The following is a description of a gene set: studied in species Mus musculus Susceptibility to Crohn's disease, a complex inflammatory disease involving the small intestine, is controlled by over 30 loci. One Crohn's disease risk allele is in ATG16L1, a gene homologous to the essential yeast autophagy gene ATG16 (ref. 2). It is not known how ATG16L1 or autophagy contributes to intestinal biology or Crohn's disease pathogenesis. To address these questions, we generated and characterized mice that are hypomorphic for ATG16L1 protein expression, and validated conclusions on the basis of studies in these mice by analysing intestinal tissues that we collected from Crohn's disease patients carrying the Crohn's disease risk allele of ATG16L1. Here we show that ATG16L1 is a bona fide autophagy protein. Within the ileal epithelium, both ATG16L1 and a second essential autophagy protein ATG5 are selectively important for the biology of the Paneth cell, a specialized epithelial cell that functions in part by secretion of granule contents containing antimicrobial peptides and other proteins that alter the intestinal environment. ATG16L1- and ATG5-deficient Paneth cells exhibited notable abnormalities in the granule exocytosis pathway. In addition, transcriptional analysis revealed an unexpected gain of function specific to ATG16L1-deficient Paneth cells including increased expression of genes involved in peroxisome proliferator-activated receptor (PPAR) signalling and lipid metabolism, of acute phase reactants and of two adipocytokines, leptin and adiponectin, known to directly influence intestinal injury responses. Importantly, Crohn's disease patients homozygous for the ATG16L1 Crohn's disease risk allele displayed Paneth cell granule abnormalities similar to those observed in autophagy-protein-deficient mice and expressed increased levels of leptin protein. Thus, ATG16L1, and probably the process of autophagy, have a role within the intestinal epithelium of mice and Crohn's disease patients by selective effects on the cell biology and specialized regulatory properties of Paneth cells. Genes up-regulated in Paneth cell (part of intestiinal epithelium) of mice with hypomorphic (reduced function) form of ATG16L1. Mouse Gene Set: CADWELL_ATG16L1_TARGETS_UP from publication Cadwell K, Liu JY, Brown SL, Miyoshi H, Loh J, Lennerz JK, Kishi C, Kc W, Carrero JA, Hunt S, Stone CD, Brunt EM, Xavier RJ, Sleckman BP, Li E, Mizushima N, Stappenbeck TS, Virgin HW 4th (PMID 18849966), and this is the list of marker genes: Inmt (indolethylamine N-methyltransferase), Ifit1bl2, Kctd14, Cyp2e1, Smyd1, Lhfpl2, Amy1, Apoc2, Bst1, Selenos, Upk1b, Npr3, Cst6, Ifit1bl1, Dhh, Gsdmc2, Tmem87a, Zkscan1, Rbp4, Scd1, Ggt1 (NCBI Gene Id 14598), G530011O06Rikx, Wfikkn2 (WAP, follistatin/kazal, immunoglobulin, kunitz and netrin domain containing 2, NCBI Gene Id 70468), Gsdmc4, Ssr1, Fmn2, Cd163, Car3, Etnppl, Xist, Rbm45, Plekhm1, Chst1, Wdfy1, Hbb-bs, Lpl, Thrsp, Alpi, Vnn1, Cfd, Cfi, Retnla, Exosc10, Ptger3, 2900026A02Rik, Cxcl1, Fcgrt, Sucnr1 (succinate receptor 1), Cit, Hba-a1, C1qtnf1, Ccdc80, Akr1b7, Adipoq, Serpina10, Neurod2, Plin1, Rhov, Hp, Gzmb, Ap1m1, Cidec, Rsad2, Lep, Tha1, Npc1l1, Ifit1, 4931408D14Rik, Gm30613, ENSMUSG00000144058, Socs3, Ccdc74a, Mttp, Fabp1, Apoa4, Hao2, Fbxo41, Trim15, Sash3, Slc36a2, Slc5a12, Fam241a, Ltk, Thpo, Pou4f1, Krt12, Pdzk1 (PDZ domain containing 1), Cd36, Gm9706, Hspa12a, Pcx, Kif3b, Fuz, Clec2h, Tmie, Exd1, Adig, Saa1, Arsk, Acaa1b, Trf, Pcdh17, Dgat2, Tmem116, Fabp4, Apoa1, Bloc1s6, Chac1, Fam3b, Plin4, Kras